The following is a description of a gene set: Binding to chondroitin sulfate, a glycosaminoglycan made up of two alternating monosaccharides: D-glucuronic acid (GlcA) and N-acetyl-D-galactosamine (GalNAc). Human Gene Set: GOMF_CHONDROITIN_SULFATE_BINDING studied in species Homo sapiens, and this is the list of marker genes: DPYSL3, RTN4RL1, IMPG1, PTN, ADGRE2, AGRN, MDK, RTN4R, AMBP, PTPRS